Given this list of marker genes Rpa1, Rev1, Rps27a, Rpa2, Rfc1, Rev3l, Pcna, Uba52rt, Ubc, Mad2l2, Rfc2, Rpa3, Polk, Ubb, Uba52, Rfc5, Rfc3, Rfc4, here is a description of the gene set: Translesion synthesis by POLK species: Mus musculus Mouse Gene Set: REACTOME_TRANSLESION_SYNTHESIS_BY_POLK